Given this list of marker genes KHK (NCBI Gene Id 3795), here is a description of the gene set: Deficiencies in KHK (ketohexokinase) are associated with essential fructosuria. part of: Diseases of carbohydrate metabolism studied in species Homo sapiens Reactome Pathway: Essential fructosuria